The following is a description of a gene set: species: Mus musculus Mouse Gene Set: GOBP_TRANSLATION The cellular metabolic process in which a protein is formed, using the sequence of a mature mRNA or circRNA molecule to specify the sequence of amino acids in a polypeptide chain. Translation is mediated by the ribosome, and begins with the formation of a ternary complex between aminoacylated initiator methionine tRNA, GTP, and initiation factor 2, which subsequently associates with the small subunit of the ribosome and an mRNA or circRNA. Translation ends with the release of a polypeptide chain from the ribosome., and this is the list of marker genes: Mrpl34, Ilf3, Mir9-1, Rps25, Mrpl50, Eef1a2, Dapk3, Rara, Rps6, Mrpl23, Qrsl1, Eif2s3y, Rgs2, Hars1, Ythdf2, Rpl28, Eif4h, Mrpl37, Rpsa, Eif3j2, Mrps16, Mrps22, Ang, Rplp0, Mrpl11, Ythdf1, Fars2, D1Pas1, Khdrbs1, Wfs1, Eif2b2, Zc3h15, Rbm4, mt-Rnr2, Mrpl38, Mrps18a, Eif1ax, Eif4a3, Wtip, Upf3b, Ucn, Cyp1b1, Polr2g, Secisbp2, Larp1, Mars1, Eif3l, Eif2b1, Lin28a, Patl2 (NCBI Gene Id 67578), Piwil4, Eif4e1b, Rpl36, Mrps2, Cnot6l, Mrpl51, Pus7, Cnot9, Mrpl58 (NCBI Gene Id 68572), Mrps30, Eif4e2, Gspt2, Bzw1, Slc35a4, Alkbh5, Eif2a, Ufsp2, Rpl10l, Igfbp5, Dapl1, Eif2d, Pcif1, Cdk4, Gatc, Rpl15 (NCBI Gene Id 66480), Mir125a, Drg1, Casc3, Mpv17l2, Mrpl13, Gcn1, mt-Tf, Eif5b, Coa3, Rpl4, Mcts2, Eif3c, Nanos2, Rpl21, Eif1ad3, Mrpl33, Rpl37, Ogt, Rpl5, Aimp2, Rplp1rt, Rpl30, Trmt10c, mt-Tn, Cirbp, Lars1, Rpusd4, Nars1, Fau, Tyms, Gfm2, Eef1e1, Tnrc6a, Srbd1, Mir1a-2, mt-Te, Gzmb, Cnot3, Rps3a1, Parp16, Tpr, Dnajc3, Rplp2, Drg2, Sesn2 (NCBI Gene Id 230784), Ufl1 (NCBI Gene Id 67490), Msi2, Mrpl57, Eif3f, Mrpl55, Rps27a, mt-Tg, Rpl10, Mrpl32, Nemf, Serbp1, Rpl9, Pld1, Mknk2, Ybx2, Uqcc2, Igf2bp2, Mrps18c, Abce1, Mir143, Eif4ebp2, mt-Tl1, Mtfmt, Tnrc6c, Qars1, Gzmc, Msi1, Nars2, Mrpl53, Eif4g3 (eukaryotic translation initiation factor 4 gamma, 3), Ifrd2, Grb7, Pum2, Rpl22, Mrps27 (NCBI Gene Id 71814), Prkca (protein kinase C, alpha), C1qbp (NCBI Gene Id 28127), Mrps35, Rpl29, Eif4g2 (NCBI Gene Id 77989), Trip4, Rpl35a, Elp6, Mrps24, Prg3, Eif4enif1, Mrpl21, Caprin2 (caprin family member 2), Rps23, Paip2, Eif5, mt-Tr, Mrps9, Eif2b5, Rpl14, Nmnat2, Rxra, Rpl24, B3gntl1, Mrpl41, Eef1a1, Upf3a, Cpeb3, Rpl37a (ribosomal protein L37a), Dazl, Sars2, Pkm, Dalrd3, Rps21, Mtif2, Eif5a, Dars2, Eif2ak1, Eprs1, Rnf14, mt-Ti, Mrpl19, Aire, mt-Rnr1, Ncbp1, Mrpl43, Aimp1, Dhx29, Mettl8 (methyltransferase 8, methylcytidine), Cdk5rap3, Eif4a2, Abtb1, Cpeb4, Elac1, Eif2ak4, Tent5b, Dapk1, Slbp, Mettl18, Rack1, Eif4a1, Mrps26, Mrps17 (mitochondrial ribosomal protein S17), Iars1, Tent2, Erbb2, Hars2, Eif1ad2, Skic8, Rpl6, Mrpl49, Neurl1a (NCBI Gene Id 80633), Ptrh1, Rps6kb1, Eif1ad15, Skic2, mt-Tp, Mrpl52, Mrps14, Eif4e, Rps15a, Ears2, Mettl17, Mrpl44, Gatb, Eefsec, Mtg2, Ankzf1, Rbms3, Map3k20 (mitogen-activated protein kinase kinase kinase 20), Rpl18, Eif1ad14 (eukaryotic translation initiation factor 1A domain containing 14), mt-Tl2, Mapkapk5, mt-Tc, Rpl8, App, Tcof1, Sars1, Mir3960, Ang5 (angiogenin, ribonuclease A family, member 5), Pym1, Cars1, Mcts1, Rpl6l, Eif4ebp1, Rars2, Trim71 (tripartite motif-containing 71), Zcchc13, Fastkd2, Rps26, Eif3k (eukaryotic translation initiation factor 3, subunit K), Mir448, Ep300 (NCBI Gene Id 328572), Rps8, Sh3bgrl, Mrpl18, Gapdhrt2, Thbs1, Aco1, Eef2k, Ptafr, Eif1ad11, Rnf25, Pcbp1, Itga2, Aars1, Larp6, Cars2, Elavl4, Nsun5, Iars2, Rpl32l, Tmed2, Prmt1, Mrpl20, Rpl10a, Mrpl14, Habp4, Mrpl40, Btg2, Xbp1, Mirlet7b, Eif3j1, Aplp1 (NCBI Gene Id 11803), Mrpl24, Eif1ad17, Otud6b, Rpl13, Mtif3 (NCBI Gene Id 76366), Lars2, Dars1, Pink1, Mapk1, Eif4a3l1, Piwil1, Rpl34, Rpl19, Usp16, Malsu1 (mitochondrial assembly of ribosomal large subunit 1), Rpl23, mt-Tt, Fech, Eif1ad16, Nanos3, Mrpl22, Mars2, Calr, Kars1, Rpl36a, Caprin1, Rida (reactive intermediate imine deaminase A homolog), Mrps25, Igf1, Aurkaip1, mt-Tv, Rps10, Paip1, Pum3, Ddx25, Chchd1, Rps24, Mrpl9, Mknk1, Zfp598, Dap, Farsa, Eif3i (NCBI Gene Id 54709), Rpl18a, Eif4a3l2, Mif4gd, Hbs1l, Ptk2b, Nsun3, Bc1, Eif1ad18, Cnot11, Gtdc1, Kbtbd8 (NCBI Gene Id 243574), Shfl, mt-Th, Mrpl16, Alkbh3, Ern1, Akt2, mt-Tm, Rpusd3 (RNA pseudouridylate synthase domain containing 3), Rpl27rt, Rps19, Bcl3, Ltn1, Eif2b3, Rps3, Tnf, Smyd5, Mrps18b, Rps13, Tob1, Limd1, Mrpl46, Usp10, Eif4ebp3, Mtrf1l (NCBI Gene Id 71580), Paip2b, Rpl35, Mrpl12, Rps12, Vars1, Dnajc1, Ptcd1, Dubr, Plxnb2, LTO1, Inpp5e, Wars1, Mtg1, Mir1247, Qki, Rps27, Ppp1r15a, Foxo3, Mrps31, Eef1g, Mrps21, Rmnd1, Mir7116, Eif2s2, Fastkd3, Srp9, Krt17, Mrps34, Ascc3, Mettl3, Rpl39, Ighmbp2, Upf1, Rps7, Cnot7, Niban1 (NCBI Gene Id 98556), Cnot10, Cnot8, Akap6, Rps16, Gapdh, Mrpl42, Eef1d, Rps2, Mir1a-1, Gemin5, Egfr, Pa2g4, Ogfod1, Gars1, Yars2, Lsm14a, Ppp1ca, Eif3d, Rpl26 (ribosomal protein L26), Cdk5rap1 (CDK5 regulatory subunit associated protein 1), Gigyf2, Gtpbp1, mt-Tw, Tnrc6b, Ago1, Akt1, Ctif (NCBI Gene Id 269037), Gfm1, Boll, Padi6, Zfp36, Nck2, Eif2b4, Eif2s1, Zar1l, Gm2044, Cpeb2, Rpl13a, Ppp1r15b, Impact (impact, RWD domain protein), Eif1ad, Ckap5, Rpl31, Ajuba, Gspt1, Rchy1, Vars2, Mir186, Wt1, Farsb, Nck1, Patl1, Gapdh-ps15, Tia1, Ptcd3, Samd4, Eif4b (eukaryotic translation initiation factor 4B), Klhl25, Eif1a, Rpl32, Mrpl54, Tsfm, Denr, Rpl7, Fxr2, Sox4, Saysd1, Igf2bp1, Etf1, Gzmn, Eif1ad12, Npm1 (NCBI Gene Id 18148), Ybx1, Rps14, Tars2, Mrps10, Mir466l, Poldip3, Trub2, Gapdhrt, Pelo, Mirlet7g, Mrps5, Pkp1, Unk, Eef1b2, Mrpl35, Mrpl30, Hbb-bs, Jmjd4, Gm6133, Prkdc, Hnrnpu, Rps29, Eif1ad4, Eif3h, Mrpl17, Lrrc47, Rcc1l, Mrrf, Rpl12, Ngrn, Syncrip, Ago3, Tsc1, Tufm, Zfp385a, Shmt2, Cnot2, Nsun4, Mettl5, Pstk (NCBI Gene Id 97429), Mvk, Mtres1, Eif2s3x, Rbm4b, Pdf, Eif1, Bank1, Aars2, mt-Td, mt-Ts1, Rpl27a, Rpl7a, Rpl9-ps6, Rps20, Gadd45gip1, Mrps23, Fmr1, Uba52, Barhl2, Rps18, Tarbp2, Eif1b, Rpl27, Ddx6, Ddx3x, Rars1, Adad1, Klhdc10, Lsm14b, Elavl1, Ngdn, Rpl17, Mrps15, Eif1ad13, Dhx36, Mrpl27, Mrpl3, Ascc2, Mrpl1, Pabpc1, Dus3l, Rpl36-ps12, Ftsj1, Fxr1, Enc1 (NCBI Gene Id 13803), Rps28, Ythdf3, Rps27l, Eif3b, Rwdd1, Rps6-ps4, Mrps28, Efl1, Aarsd1, Abcf1, Rplp1, Gtpbp2 (GTP binding protein 2), Mrpl15, Hnrnpd, Sarnp, Il6, Rpl11, Bzw2, Nat10, Rpl22l1, Rbm3, Mtor (mechanistic target of rapamycin kinase), Scrib, Ddrgk1, Alkbh1, Rps17, Ireb2, Eef2 (eukaryotic translation elongation factor 2), Taco1, Rps15, Samd4b, Rpl10-ps3, mt-Ty, Tars1, Rpl38, Mir875, Ago4, Uchl1os, Rbm8a, Mrps11, Xrn1, Rpl3, Igf2bp3, Piwil2, Shmt1, Rpl23a, Ssb, Cpeb1, Cnbp, Cyfip1, Rps6kb2, Nolc1, Trnau1ap, Wars2, Mir7b, Rps9 (ribosomal protein S9), Cnot6, Eif1ad19, Zcchc4, Eif2ak2, Pars2, Pml, Mrps12, Dap3, Guf1, Eif1ad7, Mrpl28, Mrps33, Pum1, Eif3m, Trap1, Sepsecs, Rps5, Ddx39b, Krt13, Zfp706, Eif3g, Pura, Ncbp2, Mir135a-1, Eif2ak3, mt-Ts2, Ago2, Hemk1, Mrps7, Rpl3l, Mrpl4, Nanos1, Tars3, Tcf25, Zar1, Skic3, Ncl, Yars1, Eif4e3, Eif5a2, Larp4b, Mapk3, Lrpprc, Rbm24, Mrpl36, S100a9, Mtrfr, Prr16, Rpl41, Mrpl39, Mrpl48, Mrpl10, mt-Ta, Mettl14, Ptbp1, Rps11, Trnt1 (NCBI Gene Id 70047), Rnf139, Csde1, Zfp36l1, Mrps6, Mrpl2, Magoh, Mrpl47, Eif3e (eukaryotic translation initiation factor 3, subunit E), Rps4x, Dhx33, Mtrf1, Eif3a, Mrpl45, Dhx9, Eif1ad8, Uhmk1, Eif4g1, mt-Tq, Rpl39l, Cdkal1, mt-Tk, Serp1, Prkch, Eif6, Larp4, Cnot1 (CCR4-NOT transcription complex, subunit 1)